Given this list of marker genes Bsg, Slco4c1, Slc5a8, Slc5a7, Slc22a12, Slc13a2, Slc22a8, Slco1c1, Slc16a8, Slc22a6, Avp, Slc25a10, Slco1a4, Slc44a2, Slc16a3, Slc44a4, Slc44a3, Slc25a11, Slc13a3, here is a description of the gene set: Reactome Pathway: SLC-mediated transport of organic anions studied in species Mus musculus electronically inferred by orthology from the curated human pathway part of: SLC-mediated transmembrane transport This event has been computationally inferred from an event that has been demonstrated in another species.<p>The inference is based on the homology mapping from PANTHER. Briefly, reactions for which all involved PhysicalEntities (in input, output and catalyst) have a mapped orthologue/paralogue (for complexes at least 75% of components must have a mapping) are inferred to the other species.